The following is a description of a gene set: Mouse Gene Set: GOBP_RESPONSE_TO_NUTRIENT species: Mus musculus Any process that results in a change in state or activity of a cell or an organism (in terms of movement, secretion, enzyme production, gene expression, etc.) as a result of a nutrient stimulus., and this is the list of marker genes: Becn1, Ogg1, Egfr, Fgf23, Bmp7, Lrat, Aacs, Bglap, Kdm6a, Cyp24a1, Ercc1, Maf, Slc16a1 (NCBI Gene Id 99768), Nod2, Cat, Bckdhb, Srebf1, Ogt, Csnk1a1, Abcg5, Scd1, Slc27a4, Ucp3, Slc6a19, Aldh1a2, Cyp1b1, Tfam, Gclm, Epo, Star, Prss2, Sfrp1, Apaf1, Cyp1a1, Gprin3, Abca1 (ATP-binding cassette, sub-family A member 1), Snw1, Adipor2 (adiponectin receptor 2), Gatm, Nfkbiz, Kank2, Pemt, Brip1 (NCBI Gene Id 73108), Tnc, Mn1, Cbs, Cyp27b1, Gpx1, Stc2, Cubn, Abcg8, Adsl, Lipa, Ada, Abcb1a, Lep, Mlx, Cpt1a, Spp1, Tfrc, Dpyd, Mat2a, Cdkn2d (NCBI Gene Id 12581), Cnr1, Suox, Hlcs, mt-Cytb, Tbxa2r, Kynu, Mtor, Ptgs2, Stc1, Il1a, Rbp1, F5, Plec, Slc6a4, Kat2b, Trim25, Agtr1b, Alpl, A2m, Lpl, Lct, Mlxipl, Snai2, Adipoq, Usf1, Rela, Sod2, Pdx1, Cybb, Arsa, Folr2, Map1b (NCBI Gene Id 268696), Ahcyl, Tpcn2, Penk, Bmt2, Gclc, Acacb, Ascl1, Rps6kb1, Mafb, Srf, Ccl2, Serpinc1, Pdk2, Sik2, Tspo, Nfe2l2, Gnpat, Kl, Alad, Ahcy, Gdap1, Hmgcs2 (3-hydroxy-3-methylglutaryl-Coenzyme A synthase 2), Otc, Cyp26b1, Tyr, Itga2, Ass1, Cd3e, Xbp1, Gstt1, Fabp1, Pld1, Mdm2, Vdr, C2, Ppara, Tgfb1, Col1a1, Tnfrsf11b, Agl, Ugt1a1, Pdia3, Arsb, Pim1, Acaa1a, Enpp1, Phex, Bche, Eif2ak2, Gas6, Folr1, Srsf2, Fkbp1b, Nqo1, Tmigd1, Tnks, Tyms, Prmt1, Rara, Scap, Prkcb, Pitx2 (NCBI Gene Id 338526), F7, Serpina7, Fes, Rxra, Med1, Ppard, Scd4, Mlycd, Gstp1, Usf2, Mapt, Cdkn2b, Lrp6, Acsl1, Postn, Rxrb, Bglap2, Lta, Bglap3, Dnmt3a, Sfrp2, Lipg, Ncoa1, Casr, Trim24, Igfbp2